The following is a description of a gene set: studied in species Mus musculus The chemical reactions and pathways resulting in the breakdown of compounds derived from amino acids, organic acids containing one or more amino substituents. Mouse Gene Set: GOBP_MODIFIED_AMINO_ACID_CATABOLIC_PROCESS, and this is the list of marker genes: Ggt7, Ahcy, Hoga1, Ahcyl, Mthfsl, Pcyox1l, Pm20d2, Abhd12b, Abhd16b, Dio2, Aasdhppt, Aldh1l1, Dmgdh, Abhd16a, Dpep1, Ggact, Ggt1, Aldh1l2, Sardh, Pcyox1, Abhd12, Bhmt, Ggt5, Dio3, Chac1, Agxt2, Acadl, Chac2